Given this list of marker genes MAPK3, RPS27A, PSMB1, UBC, PSMC4, SMAD4, PSMB4 (proteasome 20S subunit beta 4), NKX3-2 (NCBI Gene Id 579), HDAC4, PSMD3, AKT3, PPM1D, YES1, WWTR1, HEY1, PSMC5, HDAC3, GLI2, UBB, ABL1 (ABL proto-oncogene 1, non-receptor tyrosine kinase), PSMA7, HEY2, PSMB5, UBA52, PSMB7, CUL1, PSMD7, SMURF1, UCMA, CCNB1, HIVEP3, DLX5, SRC, RB1, PSMD2, PSMC2 (proteasome 26S subunit, ATPase 2), BMP2, PSMA1, MSX2, PSMB6, PSMA4, CCND1, CBFB, HDAC6 (NCBI Gene Id 100820762), PSMD1, SEM1, PSMA3, AR, HAND2 (NCBI Gene Id 9464), HES1, SKP1, PSMD13, MMP13, PSMA5, CDKN1A, YAP1, RUNX1, RBM14, DLX6, PPARGC1A, PSMD8, CDK4, PSMA2, BAX, NR3C1, RBX1, CDK1, PSMC1, ESRRA, GLI3, LGALS3, ZNF521, ITGBL1, ESR1, BGLAP, PSMD12, STAT1, SMAD1, ADRM1, RUNX2, PSMD6 (proteasome 26S subunit, non-ATPase 6), GSK3B, SKP2, PSMC6, MAPK1, MAF, STUB1, PSMB2, PSMC3, TWIST1, AKT2, PSMA6, ITGA5, WWP1, SMAD6, PSMB3, TWIST2, PSMD11, SATB2, IHH, PSMD14, SP7, COL1A1, AKT1, PPARGC1B, SOX9, here is a description of the gene set: Reactome Pathway: Transcriptional regulation by RUNX2 part of: Generic Transcription Pathway studied in species Homo sapiens RUNX2 (CBFA1 or AML3) transcription factor, similar to other RUNX family members, RUNX1 and RUNX3, can function in complex with CBFB (CBF-beta). RUNX2 mainly regulates transcription of genes involved in skeletal development. RUNX2 is involved in development of both intramembraneous and endochondral bones through regulation of osteoblast differentiation and chondrocyte maturation, respectively. RUNX2 stimulates transcription of the BGLAP gene, which encodes Osteocalcin, a bone-derived hormone which is one of the most abundant non-collagenous proteins of the bone extracellular matrix. RUNX2 directly controls the expression of most genes associated with osteoblast differentiation and function. RUNX2-mediated transcriptional regulation of several genes involved in GPCR (G protein coupled receptor) signaling is implicated in the control of growth of osteoblast progenitors. RUNX2 promotes chondrocyte maturation by stimulating transcription of the IHH gene, encoding Indian hedgehog. Germline loss-of-function mutations of the RUNX2 gene are associated with cleidocranial dysplasia syndrome (CCD), an autosomal skeletal disorder. The function of RUNX2 is frequently disrupted in osteosarcoma. Vitamin D3 is implicated in regulation of transcriptional activity of the RUNX2:CBFB complex.<p>RUNX2 expression is regulated by estrogen signaling, and RUNX2 is implicated in breast cancer development and metastasis. Besides estrogen receptor alpha (ESR1) and estrogen-related receptor alpha (ERRA), RUNX2 transcription is also regulated by TWIST1 (Yang, Yang et al. 2011), glucocorticoid receptor (NR3C1), NKX3-2 (BAPX1), DLX5 and MSX2. RUNX2 can autoregulate, by directly inhibiting its own transcription. Several E3 ubiquitin ligases target RUNX2 for proteasome-mediated degradation: STUB1 (CHIP), SMURF1, WWP1, and SKP2. Besides formation of RUNX2:CBFB heterodimers, transcriptional activity of RUNX2 is regulated by binding to a number of other transcription factors, for example SOX9 and RB1.<p>RUNX2 regulates expression of several genes implicated in cell migration during normal development and bone metastasis of breast cancer cells. RUNX2 stimulates transcription of the ITGA5 gene, encoding Integrin alpha 5 and the ITGBL1 gene, encoding Integrin beta like protein 1. RUNX2 mediated transcription of the MMP13 gene, encoding Colagenase 3 (Matrix metalloproteinase 13), is stimulated by AKT mediated phosphorylation of RUNX2. RUNX2 is implicated in positive regulation of AKT signaling by stimulating expression of AKT-activating TORC2 complex components MTOR and RICTOR, which may contribute to survival of breast cancer cells.<p>RUNX2 inhibits CDKN1A transcription, thus preventing CDKN1A-induced cell cycle arrest. Phosphorylation of RUNX2 by CDK4 in response to high glucose enhances RUNX2-mediated repression of the CDKN1A gene in endothelial cells. In mice, Runx2-mediated repression of Cdkn1a may contribute to the development of acute myeloid leukemia (AML). RUNX2 can stimulate transcription of the LGALS3 gene, encoding Galectin-3. Galectin 3 is expressed in myeloid progenitors and its levels increase during the maturation process (Le Marer 2000).<p>For a review of RUNX2 function, please refer to Long 2012 and Ito et al. 2015.